The following is a description of a gene set: from publication Chen Y, Wang X (PMID 31504780) Genes predicted to be targets of miRBase v22 microRNA hsa-miR-6777-5p in miRDB v6.0 with MirTarget v4 prediction scores > 80 (high confidence targets). species: Homo sapiens Human Gene Set: MIR6777_5P, and this is the list of marker genes: EPHB4, ARHGDIA, PCSK6, MTSS2, CELSR2, EFHD2, PLGLB1